Given this list of marker genes SYT13, CYP4X1, FRZB, RSPO3, CLDN10, TMEM108, LGR6, SPIB, NLRP7, FRAS1 (Fraser extracellular matrix complex subunit 1), CD200, LGR5, COL9A3, IL17RD, SFRP1, TCIM, CLDN3, SLC35F3, PEG10, NLGN4X, SYNPO2, COL22A1, LINC02984, EDAR, LSAMP, CRABP1, STXBP6, PON3, TSPYL5, TNFRSF11B, LTO1, DAPL1, HSPD1, ANKRD6, CYP24A1, PARM1, ZNF711, ODAM, PABPC4L, OCA2, PCDHB2, IL13RA2, HPGD, MYB, HOXD13, FDCSP, GPR27, TSPAN8, DLX1, PCOLCE2, MOXD1, SBSPON, TSPAN2, PTX3, PPFIA1, MAP7D2, POU2AF3, COL9A2, ZNF704, AS3MT (arsenite methyltransferase), DMD, ZIC2, FABP6, BCL2, PLCB4, UCHL1, SELE, CENPV, GABRP, ERP27, SOSTDC1, PRRX1, TMSB15A (thymosin beta 15A), RNF150, CECR2, CLDN11, RBP7, MYCN, NPTX2, FGF19, ADAM23, STAR, AFAP1-AS1 (AFAP1 antisense RNA 1), PRAME, DLX2, ARNT2, OLFM1, NRCAM, GPR158, CRACD, ZNF483 (zinc finger protein 483), GPC4 (glypican 4), RASGEF1A, SVIP, LIFR, LAMA1, PENK, LEMD1, VASH2, CXCL5, ADD2, GARIN5A, SHISA2, ADGRE1 (NCBI Gene Id 2015), here is a description of the gene set: Cluster a: genes identifying an intrinsic group in head and neck squamous cell carcinoma (HNSCC). studied in species Homo sapiens Propensity for subsequent distant metastasis in head and neck squamous-cell carcinoma (HNSCC) was analysed using 186 primary tumours from patients initially treated by surgery that developed (M) or did not develop (NM) metastases as the first recurrent event. Transcriptome (Affymetrix HGU133_Plus2, QRT-PCR) and array-comparative genomic hybridization data were collected. Non-supervised hierarchical clustering based on Affymetrix data distinguished tumours differing in pathological differentiation, and identified associated functional changes. Propensity for metastasis was not associated with these subgroups. Using QRT-PCR data we identified a four-gene model (PSMD10, HSD17B12, FLOT2 and KRT17) that predicts M/NM status with 77% success in a separate 79-sample validation group of HNSCC samples. This prediction is independent of clinical criteria (age, lymph node status, stage, differentiation and localization). The most significantly altered transcripts in M versus NM were significantly associated to metastasis-related functions, including adhesion, mobility and cell survival. Several genomic modifications were significantly associated with M/NM status (most notably gains at 4q11-22 and Xq12-28; losses at 11q14-24 and 17q11 losses) and partly linked to transcription modifications. This work yields a basis for the development of prognostic molecular signatures, markers and therapeutic targets for HNSCC metastasis. from publication Rickman DS, Millon R, De Reynies A, Thomas E, Wasylyk C, Muller D, Abecassis J, Wasylyk B (PMID 18679425) Human Gene Set: RICKMAN_HEAD_AND_NECK_CANCER_A